The following is a description of a gene set: studied in species Homo sapiens The presence of a neoplasm of the large intestine. Neoplasm of the large intestine Human Gene Set: HP_NEOPLASM_OF_THE_LARGE_INTESTINE, and this is the list of marker genes: FLCN, NTHL1, RPS19, AXIN2, SDHD, RAD54B, PTPRJ (protein tyrosine phosphatase receptor type J), SMAD7, SDHC, DOCK8, BRCA2, KRAS, BAX, CHEK2, BRAF, MLH3, PMS2, APC, MSH6, RPL35, POLE, EP300, POLD1, FOXE1, MLH1, TGFBR2, KLLN, ATM, C1S, RPL18, STK11, GREM1, SDHA, MSH2, RPS26, PIK3CA, RPS29, MSH3, PMS1, RPL5 (ribosomal protein L5), DLC1, PDGFRL, MST1, NF1 (NCBI Gene Id 646021), EPCAM, MCC, RPL15, RABL3, MDM2, SRC, PDGFRA, CTNNB1, RPL35A, CDKN2A, HABP2, BUB1B, AAGAB, CCND1, SMAD4, GPR35, BLM, PRKAR1A, MUTYH, ADA2, RPS7, COL14A1, RPS10, BRCA1, SEMA4A, ENG, RPL8, SDHB, KEAP1, NRAS, RPL9, RPL31, MINPP1, BMPR1A, TCF4, PALB2, BUB3, TLR2, RPL11, RPS27, DICER1, TSR2, KIT, PTPN12, RPS17 (ribosomal protein S17), AURKA, RPL27, RPS24, RPS15A, RPS28, GATA1, TRIP13, RNF43, RPL26, CEP57, RPS20, DCC, PALLD, SEMA4D, HEATR3, PDE11A, MBD4, PTEN, PLA2G2A, TP53, SEC23B (NCBI Gene Id 980), USF3, AKT1, BUB1 (BUB1 mitotic checkpoint serine/threonine kinase), MAD1L1, FGFR3